Given this list of marker genes Neurog1, Chrnb2, Atp8b1, Npr2, Nrp2, Slitrk6, Pou4f3, Tifab, Pax2, Nrp1, here is a description of the gene set: studied in species Mus musculus Mouse Gene Set: GOBP_VESTIBULOCOCHLEAR_NERVE_DEVELOPMENT The process whose specific outcome is the progression of the vestibulocochlear nerve over time, from its formation to the mature structure. This sensory nerve innervates the membranous labyrinth of the inner ear. The vestibular branch innervates the vestibular apparatus that senses head position changes relative to gravity. The auditory branch innervates the cochlear duct, which is connected to the three bony ossicles which transduce sound waves into fluid movement in the cochlea.